The following is a description of a gene set: from publication Chen Y, Wang X (PMID 31504780) Human Gene Set: MIR659_3P Genes predicted to be targets of miRBase v22 microRNA hsa-miR-659-3p in miRDB v6.0 with MirTarget v4 prediction scores > 80 (high confidence targets). species: Homo sapiens, and this is the list of marker genes: DESI1, LPGAT1, PRPH, CA1, TRAM1, RNF4, PCSK2, FBXW2, MFAP3L, DOCK9, LDLRAP1, HLA-DQA1, ARPP21, WNK1, IL1RAP, CCNT2, SERPINB4, NFATC1, CLIC5, FGF14, TNFRSF19 (TNF receptor superfamily member 19), PHF21A, CABP1 (NCBI Gene Id 9478), ENTPD4, ZNHIT6, TENT5C, ARHGEF12, TSC22D2, ARFGEF2, SLC35F1, HDGFL3, NRBF2, CAPZA1, RAC1, CLP1, DUSP10, TDRD10, NEK7, RYBP, HLCS, CDKL2, IGSF23, POU2F1 (NCBI Gene Id 7823), SLC36A3, DDHD2, ARID1B, KIF13A, GTF2H1, AUTS2, SPHK1, ZPBP2, TFDP2, ZBTB21, CREBZF (NCBI Gene Id 58487), ADIPOR2 (adiponectin receptor 2), GATC, PSMD11, AGPAT3, SCML2 (Scm polycomb group protein like 2), KDM4A, DOK6, RGPD5, ZBTB34, CLINT1, BMF, IRS2, INSIG1, LDAH, IGF2BP2, PWWP3B, FBN1, EMC4, CRIM1, FGF18, RNF6, SORL1, RIMKLA, TRUB1, MRTFB, RALBP1, INHBB, DEPDC1, NOTCH2, RGPD8, RICTOR, FOXP1, JPH1 (NCBI Gene Id 56704), MAPK9, BCLAF1, FRMD6, SLC25A24, RANBP9, PSMF1, HOXA11, STMP1, ENOX2, CSNK2A2, LRIG3, UGCG, ERF, CXXC5, DTNA, NCOR2, PSMA1, CTNND1, IRX3, PRUNE1, SMURF2, ATL2, MAGT1, SRSF10, CBLN2, PPP1CB, ATAD2B, USP31, NRAS, LYSMD2, NAA15, CSGALNACT1, EPGN, SERPINB3, CREBRF, SLC12A2, ARHGEF10, BMP2K, SH3D19, FGF12, TAPBP, MEF2C, GRIA4, SMARCC1, PTPN9, FMNL2, CLVS1, DYNC1LI2, ANKH, LYVE1, LDLR, PRKG2, PMP22, MAP7, CNOT6L, KLHL42, TMCC1, FSD1L, PLEKHA2, LRRTM3, POU2F2, SLC30A7, PIK3C2A, JAKMIP2, ANKRD13C (ankyrin repeat domain 13C), SLC35F3, CPEB1, NAP1L1, HIPK2, FGD4, FRZB, SNX7, CCNY, EFCAB14, LMNTD2, NLK, ACTN4, MAGI2, UBE3C, SLITRK5, MAX, ARID1A, SOCS2, ZBTB20, LIN28B, INO80, DCLK1, KCTD6, ITM2C, PDS5B, GADD45A, RBMS3, PYGO2, FNIP1, GIMAP2, LRP8, PIGC (phosphatidylinositol glycan anchor biosynthesis class C), CDH8, CBFA2T2, ARF6, FAT1, LSM14B, FAM107B, DIO2, NEDD9, GABRB2, ADSS2, MINDY2, MIER3, BACE2, PIGT, NR2E1, STIM1, ONECUT2, MARCHF1, ZDHHC20, CRBN, TRAT1, KALRN (kalirin RhoGEF kinase), PABPC4L, CDK19, GORASP2, ARAP3, ABCC1, YPEL2, SCN8A, ZNF85, EDEM3 (NCBI Gene Id 87240), BDNF, GDNF, LTO1 (NCBI Gene Id 72284)